The following is a description of a gene set: Human Gene Set: GOBP_INORGANIC_ION_IMPORT_ACROSS_PLASMA_MEMBRANE species: Homo sapiens The directed movement of inorganic ions from outside of a cell, across the plasma membrane and into the cytosol., and this is the list of marker genes: KCNJ2, TRPM4, FXYD2, KCNJ5, KCNQ1, ATP1B2, KCNH2, CACNA1S, ATP1A2, SLC39A14, SLC12A7, ATP1B1, SLC9A9, TRPV5, KCNK9, KCNJ11, SLC12A4, KCNJ16, MIR448 (microRNA 448), ABCC9, PPP3CC, SLC9A4, CACNA1C, SLC39A8, KCNJ15, LCN2, SLC9C1, KCNJ3 (potassium inwardly rectifying channel subfamily J member 3), ATP1A1, SLC30A5, P2RX5, KCNJ9, MIR103A1, SLC9A3, KCNJ12, SLC24A1, SLC12A8 (NCBI Gene Id 84561), PPP3R2, SLC5A1, IFNG, SLC8A3, SLC9A1, SCNN1G, SLC12A2, SLC12A5, TRPM1, CACNA1B, TRPV1, ATP1A4, HCN1 (hyperpolarization activated cyclic nucleotide gated potassium channel 1), KCNE2, TRPV6, SLC24A4, ASIC5, KCNN4, STK39, SLC39A5, STEAP2, SCNN1A, ATP2B4, SLC6A1, PPP3CA, CNGA3, SLC8A1, KCNJ4, SLC24A2, SLC8A2, GRM6, SLC30A1, KCNJ14, SLC5A2, CACNA1G, ANK2, MIR208A, PCSK9, TRPM2, TRPV4, TRPV3, PPP3R1, KCNJ1, KCNJ18, NEDD4L, MIR200C, HCN2 (hyperpolarization activated cyclic nucleotide gated potassium and sodium channel 2), MIR208B, ATP1B3, SLC39A6, NALF2, KCNK5, KCNJ8, MIR26A1, AKAP5, P2RX1, SLC9A5, SCNN1B, ATP1A3, KCNJ13 (NCBI Gene Id 619535), KCNJ6, SLC39A11, SLC34A1, SLC9A7, PRNP, SLC39A10, CACNA1H, SLC12A3, ABCC8, AQP8, CACNA1I, SLC39A4, SLC39A12, MIR30D, KCNJ10, CACNA1E, HCN4, SLC9C2, FYN, ATP4B, CACNA2D1, CACNA1A, SLC30A8, HCN3 (NCBI Gene Id 57657), MIR210, SLC12A6, SCNN1D, CACNA1F, SLC9A2, SLC5A6, TRPV2, PPP3CB, ISCU, ATP4A, ATP12A, NALF1, SLC9A6, MIR24-1, MS4A1, DLG1, CACNA1D, SLC12A1